Given this list of marker genes DENND4C, RAB3GAP2, TRAPPC10, TRAPPC9, RINL, GDI2, DENND4B, RAB14, RAB13, RAB3IP, RAB32, ALS2CL, RGP1, HPS1, TRAPPC2L, DENND4A, ANKRD27, ALS2, CHM, RAB5C, AKT2 (NCBI Gene Id 208), GDI1 (GDP dissociation inhibitor 1), TRAPPC8, TRAPPC4, MON1B, RAB3GAP1, DENND5B, TRAPPC3, RAB6B, CHML, RAB31, HPS4, RAB8A, DENND2D, TRAPPC13, RAB3A, RAB39A, RIC1, RAB6A, CCZ1B, RAB38, RAB1B, YWHAE, DENND1B, RIN2, GAPVD1 (GTPase activating protein and VPS9 domains 1), RAB7A (NCBI Gene Id 7879), DENND2C, RAB9A, RAB5B, CCZ1, RAB1A, DENND2B, RAB12, RAB8B, ULK1, TRAPPC12, TRAPPC5, AKT1, RAB9B, RAB27B, RAB10, DENND1C, DENND6A, RIN3, MON1A, RAB3IL1, TRAPPC6A, RAB7B, RAB18, TRAPPC11, MADD, RIN1, RAB5A, DENND2A, RAB39B, TRAPPC1, AKT3, RAB35, RAB27A, DENND6B, TRAPPC6B, SBF2, DENND1A, RABGEF1, DENND3, SBF1, RAB21, DENND5A, TRAPPC2, here is a description of the gene set: species: Homo sapiens Human Gene Set: REACTOME_RAB_GEFS_EXCHANGE_GTP_FOR_GDP_ON_RABS RAB GEFs exchange GTP for GDP on RABs